The following is a description of a gene set: A series of processes that forms an integrated mechanism by which a cell or an organism detects the depletion of primary nitrogen source, usually ammonia, and then activates genes to scavenge the last traces of the primary nitrogen source and to transport and metabolize alternative nitrogen sources. The utilization process begins when the cell or organism detects nitrogen levels, includes the activation of genes whose products detect, transport or metabolize nitrogen-containing substances, and ends when nitrogen is incorporated into the cell or organism's metabolism. Human Gene Set: GOBP_NITROGEN_UTILIZATION species: Homo sapiens, and this is the list of marker genes: BCL2, ASL, NR1H4, LGSN, BAX